The following is a description of a gene set: A reduction of corneal clarity. Human Gene Set: HP_CORNEAL_OPACITY studied in species Homo sapiens Corneal opacity, and this is the list of marker genes: CEP57, GLA (NCBI Gene Id 2717), EP300, TRIM44, CTSA, AIRE, EPHX2, KRT5, SLC4A4, PPP1R13L, CHUK, SLC29A3, POLR3A, PEX3, PIGG, GTF2IRD2, RPGRIP1L, TMEM216, LETM1, NCF1, GJB3, TMEM270, CRYGC, XPR1, MPV17 (mitochondrial inner membrane protein MPV17), XPA, POMT1, SMARCAL1, IL2RA, TCF4, NEU1, B3GALNT2, ELP1, LIMK1, JAG1, PIGN, MAB21L2, PEX12, GNPTAB, BUB1, PEX1, ESCO2, GUSB, SC5D, CPLX1, PIK3R1, FLG, CSPP1, RAX, ERCC6, KRAS, ATP7B (ATPase copper transporting beta), TBCE, CENPF, RPGRIP1, KRT14, LIFR, COLEC10, EIF4H (eukaryotic translation initiation factor 4H), BUB1B, B9D2, COL4A1, IDS, POMK, PCSK9, TBCK, MCOLN1, CRYAA, ZNF469, HRAS, FUCA1, DDB2, MBTPS2, CEP290, MAPKAPK5, APOB, MAFB, GTF2I, MMP2, HMX1, TBX1, DNA2, PEX5, OCRL, DNAJC30, PTPN22, FOXC1, ABCG8, MYOC, TMEM67, NEUROG1, GBA1, UROS, SLC25A24, ABCA1, BUB3, OTUD5, TBL2, MAF, IDUA, WDR73, FERMT1, LARGE1, MMP14 (NCBI Gene Id 4323), FKRP, PCYT1A, NDP, BUD23, APOA2, PEX14, ERCC4, GRHL2, NTRK1, MT-CYB, PRDM12, PIGL, B4GAT1, COL8A2, ERCC8, PLXND1, XPC, TACSTD2, PXDN, CLIP2, FRAS1, VSX2, ALDH18A1, LDLR, TMEM237, B9D1, NSD2, TCTN3, SLC4A11, COL11A1 (collagen type XI alpha 1 chain), ASAH1, ZEB1, COL7A1, FKBP6, KERA, TRIP13, VSX1, STX1A, TGFBI, PDGFRB, SIX6, COX7B, SCARF2, ZMPSTE24, COL17A1, APOA1, RXYLT1, GJB2 (gap junction protein beta 2), TMEM107, STS, CRYBB2, COL18A1, CRYBA4, CC2D2A, STAT4, GTF2IRD1, PPP1R17, ALDH3A2, DYRK1A, FBLN5, PDGFB, TMEM231, GJA1, SREBF1, NDUFB11, GHR, PEX11B, LRP5, POLA1, ST14, JAM2, NRAS, NOD2 (NCBI Gene Id 8135), ERCC5, ELN, AGBL1, FLNB, CHST6, TXNDC15, TAT, MAB21L1, CREBBP, GLB1, KIF11, MYORG, YAP1, GJA8, MKS1, CPAMD8, KDSR, HCCS, VAC14, SOX2, LMNA, GJB4, PEX13, SUMF1, PEX2, PAX6, CHRDL1, REV3L, LCAT (NCBI Gene Id 3931), ATOH7, B3GALT6, FZD4, ATAD3A, CRPPA, TCTN1, FKTN, NGLY1, POMT2, POMGNT2, TRPV3, NELFA, OVOL2, RAB23, CD247, PORCN, TCTN2, VPS37D, RBM8A, OCLN, ANKRD55, GNPTG (NCBI Gene Id 84572), CTNS, TENM3, ERCC2, GALNS, PITX2, ZFHX2, PTPN2, PEX16, BAZ1B, TRPV4, NCAPG2, PEX26, PRDM5 (PR/SET domain 5), DST, GNAS, APOE, ARSB, TEK, IKBKG, NAGA, PEX19, CRYGD, CTBP1, B3GLCT, NLRP3, RFC2, PLCB3, DAG1, CYP1B1, FGFR1, FIG4, PITX3 (NCBI Gene Id 5309), UBIAD1, KRT12, LIPC, POMGNT1, PSMB8, CYP4V2, BMP4, RIPK4, DYM, CRYBB1, WT1, MAN2B1, SLC20A2, PEX6 (peroxisomal biogenesis factor 6), DHCR7, PEX10, TWIST2, FOXE3, ERCC3, METTL27, LTBP2, IL2RB, TRAPPC2